The following is a description of a gene set: from publication Xie X, Lu J, Kulbokas EJ, Golub TR, Mootha V, Lindblad-Toh K, Lander ES, Kellis M (PMID 15735639) Comprehensive identification of all functional elements encoded in the human genome is a fundamental need in biomedical research. Here, we present a comparative analysis of the human, mouse, rat and dog genomes to create a systematic catalogue of common regulatory motifs in promoters and 3' untranslated regions (3' UTRs). The promoter analysis yields 174 candidate motifs, including most previously known transcription-factor binding sites and 105 new motifs. The 3'-UTR analysis yields 106 motifs likely to be involved in post-transcriptional regulation. Nearly one-half are associated with microRNAs (miRNAs), leading to the discovery of many new miRNA genes and their likely target genes. Our results suggest that previous estimates of the number of human miRNA genes were low, and that miRNAs regulate at least 20% of human genes. The overall results provide a systematic view of gene regulation in the human, which will be refined as additional mammalian genomes become available. studied in species Homo sapiens Genes having at least one occurrence of the highly conserved motif M154 RNCTGNYNRNCTGNY in the regions spanning 4 kb centered on their transcription starting sites. The motif does not match any known transcription factor binding site. Human Gene Set: RNCTGNYNRNCTGNY_UNKNOWN, and this is the list of marker genes: HAPSTR1, TNS2, BEST4, CALD1, PICK1, SORBS2, PAK3, LINC01101, SLC27A4, BCL11B, C4A, TMSB4XP6, ACVR2A, FERD3L, HOXA10, NRG2, MID1, ZNF541, IL22RA1, TYRO3, ADAMTSL1, PPTC7, TMSB4XP4, BMP1, CHRM1, PCF11, VEGFA (NCBI Gene Id 7422), DUSP6, CLVS1, TBCB, TUFT1, FAM83E, EFNB1, ANXA9, KLB, RARA (retinoic acid receptor alpha), SPARC, HOXB9, NBEA, ATXN7L1, NSG2 (neuronal vesicle trafficking associated 2), RC3H2, EHF, HCRT, ELMOD1, BMP6, INKA1, TNRC6A, NLGN2, FZD9, ANK2, NKX2-1, SRCIN1, HOXD12, POLR2I, ARID1A, RAB5B, LARP4, ALKBH6, ZMYND8, CNTFR, H2AC1, KIF7, SLC2A9, ZNF267, MOAP1, TMSB4XP8, TCF20, MBNL2, PLCXD2, NRK, SPACA6, LENG9, ID1, H2BC1, LIX1L, DNAJB8, C4B, ANKS1B, RNASE11, ZBTB18, ATP13A4, TMSB4Y, TRIM69, SOBP, TMSB4XP1, NOS3